The following is a description of a gene set: Genes down-regulated in allogeneic T cells after stimulation with dendritic cells from: peripheral lymph nodes (mLN) versus spleen. Human Gene Set: GSE5503_PLN_DC_VS_SPLEEN_DC_ACTIVATED_ALLOGENIC_TCELL_DN Transcriptional response of murine allogeneic T cells (B10.BR) after stimulation with different organ-derived (spleen, liver, peripheral and mesenteric lymph nodes) dendritic cells (C57BL/6) in vitro species: Homo sapiens from publication Kim TD, Terwey TH, Zakrzewski JL, Suh D, Kochman AA, Chen ME, King CG, Borsotti C, Grubin J, Smith OM, Heller G, Liu C, Murphy GF, Alpdogan O, van den Brink MR (PMID 18178870), and this is the list of marker genes: AXIN1, SELENOS, NAB2, EZH1, RIGI, SIPA1L1, AGPAT3, ZC3H7A, DNAJC13, WAC, IL10RB (NCBI Gene Id 3588, interleukin 10 receptor subunit beta), KRAS, KLRD1, PSMF1, MBP, ACTR10, RAP2B, BMAL1, SYT11 (synaptotagmin 11), ENTPD5, SELPLG, SACM1L, RPL18A, RPS27, NRBP1, CD3E, DEGS1, PPP1R12C, B4GALT1 (NCBI Gene Id 2683), SIKE1, GCC2, INTS8, LRRC8A, TIMP2, FBXO25, RPS16, AQR, MAN1A2, GINM1, ZSCAN20, NUDT4, DDX54, KXD1, CHID1 (NCBI Gene Id 66005), RHOG, TBC1D4, ALG11, MRPS24, HERC1, AR (NCBI Gene Id 367), TLE4, SLFN13, RAF1, C1orf122, MAML1, MDH2 (NCBI Gene Id 4191), ATG16L2, TRAF3, MARCO, ACTR8, THOC5, ATF7IP, CANX, BOD1L1, PARP6, ZBTB6, CREBL2, ANAPC16, UBE2B, SLC9A9 (solute carrier family 9 member A9), HOOK1, TRIM8, EIF2B4, PYCARD, MRTFA, TNFRSF1B, GPR107, ANKRD39, HSPH1, NRBF2, IFIH1, ATPSCKMT, AFG2B, SZT2, GSDMD, CMTM6, ITPR2, SMC5, ZEB1, IL4R, LETM1, FBXL5, SETX, MTERF2, GK2, CASP6, CD37, ABI1, WDR7, SEC11A, XDH, SMURF2, AUH, ATOSA, CCNT2, OSBPL11, IKZF1, KLK8, DCUN1D2, TMEM160, CSNK1G1, ANTKMT, ZW10, KPNA4, GTPBP2, MTFMT, B3GNT2, GCH1, C22orf39, PTPRC, COX17, TSPO, HS3ST4, HCFC2, CCPG1, IL27RA, NDRG3, PKP4, PHF23, MIEN1, PRR13 (proline rich 13), WAS, ATP1B1, CCR6, DNAJC8, EPAS1, TMEM234, RNF114, ANAPC10 (NCBI Gene Id 25866), RIOX2, CPEB4, TNFRSF18, DENND4C (DENN domain containing 4C), BIRC2, KAT2B, ATP8B2, ARV1, TRIM39, ZYG11B, RNF167, DTX2, GIN1, HBB, OSTM1, ADCY7, CCDC115, SART1, DENR, RHOH, KATNBL1, MTMR6, DOK5, RPRML, SMC4, FYCO1, NUMA1, TMEM258, DIPK2A, DNAAF1, MYO1E, PPP2R5A (NCBI Gene Id 5525), NSD3, PPRC1, EIF2B5, CAT, LANCL3, DAAM1 (NCBI Gene Id 23002), SLA2, EFR3A, MFSD2A, IDS, CAPN1, AKIRIN1, TMEM179B, DYNLRB1, FASTKD2, C2orf88, SPO11, AEBP2, GDAP2, TSTD2, LRP10, SUN3, CSNK2A1, ENSA, ARF6, MTMR4, VPS28, ZBTB7B, SEM1